Given this list of marker genes PSMB1, MIRLET7A1, YES1, PIK3R3, SUZ12, RICTOR, H2BC4, PAK1, TRAV19, MIR34A, AGO3, ICOS, FOS, PRKAG1, OS9, PPP2R5D, MIB2, HLA-DRB5, PPP2CA, STAT3, PPP2R1A, H2BC9, EP300, MOV10, H2BC13, RBBP5 (RB binding protein 5, histone lysine methyltransferase complex subunit), SRC, MIR142, PSMD11, CD3E, PSMA5, PSMC5, PPP2R5A, HLA-DPB1, H2AZ2, CREBBP, HIF1A, CD3G, PSMC6, CD3D, PSMD1, IRF1, TEAD3, MIR148A, MAGT1, CD80, PIK3R1, CSNK2B, H4C1, CSK, PPP2R1B, TRAC, LYN, CTLA4, UBB, PIK3CD, PSMC3, RBBP4, H3-3A, BTRC, H2BC26, MIR34C, PSMC2, PPP2R5B, PSMA6, HLA-DQB2, MAPKAP1, HLA-DQB1, AKT2, CSNK2A2, H2AC20, BTLA, CUL3, PRKAG2, PDCD1LG2, MIR429, TRAV8-4, PRKAA2, EED, MTOR, AGO4, H2BC1, M, MYC (NCBI Gene Id 731404), H2AC14, WDR5, MIR152, H3C1, GRB2, NEK2, PSMA2, CCND1, CD247, N, PSMB4, HLA-DRB1, PSMA7, RNF185 (ring finger protein 185), DDOST, MIR200C, CSNK2A1, JAK1, SPOP, TEAD4, PSMB7, KMT2A, AKT1, PIK3CG, TUSC3, H2BC12, PIK3CB, VCP, TRBV12-3, RBBP7, H2BC3, ADRM1, MAP3K14 (NCBI Gene Id 9020), MIR34B, AGO2, STT3A, PAK3, PDCD1, SEM1, PSMD3 (NCBI Gene Id 94019), NFE2L2, RELA (NCBI Gene Id 5970), UBC, TMEM258, STAT1, THEM4, TNRC6B, PIK3R5, GRAP2, NFKB2, DERL3 (derlin 3), YWHAG, RBX1, DERL1 (NCBI Gene Id 79139), VAV1, OST4, HLA-DRA, PSMD2, CDK4, GSK3B, UBA52, AKT3, WWTR1, PSMA4, HLA-DQA2, TRAV29DV5, STT3B (NCBI Gene Id 201595), H2AC6 (NCBI Gene Id 8334), PRR5, ICOSLG, COPS5, PSMA3, H2AJ, KMT2C, BRD4, SKP1, H2BC15, PSMA1, PSMD8, PDPK1, PSMB3, MLST8, RNF5, H2AX, TRBV7-9, PSMC1, ERLEC1, CDC42, H2AB1, TCF7, EPAS1, TEAD1, ASH2L, PSMB6, CTNNB1, DAD1, MIR340, HLA-DQA1, HLA-DPA1, MIR424, PRKAB1, PRKAB2, DPY30, JUN, TRIB3, CD274, PPP2R5E, NFKB1, H2AC18, OSTC, H2BC12L, JUND, AGO1, CUL1 (NCBI Gene Id 8454), PPP2CB, MIR140, TCF7L2, PSMC4, RPS27A, ATF3, FYN, LCK, PIK3R2, YAP1, H2BC5 (NCBI Gene Id 3017), PTPN11, TNRC6A, CD86, RPN1, ERLIN1, TNFRSF14, PSMB5, PSMD7, PSMD12, H2AC4, PAK2, MIR93, CD4, PSMB2, FOSB, PSMD14, MYCN, TNRC6C, PRKAG3, CD28, RPN2, B3GNT3, HLA-DRB3, PPP2R5C, H3C15, H2AC7, DERL2, HLA-DRB4, PIK3R6, TRBC1, RAC1, MIR138-1, H2BC17, MAP3K8, PSMD6, TEAD2, MIR200B, SEL1L, LEF1, H2BC14, ERLIN2, PSMD13, PTPN6, PRKAA1, PIK3CA, TCF7L1, H2BC21, H2BC11, EZH2, here is a description of the gene set: Reactome Pathway: Regulation of T cell activation by CD28 family Optimal activation of T lymphocytes requires a carefully orchestrated interplay between two key signals. The first signal originates from the T cell receptor (TCR) recognizing a specific antigen. However, this initial encounter is insufficient on its own. A crucial "costimulatory" signal is needed for full T cell activation, delivered by the engagement of costimulatory receptors, such as CD28, on the T cell surface with their corresponding ligands on antigen-presenting cells (APCs) (Chen & Flies 2013, Acuto et al. 2003, Slavik et al. 1999). <br>The CD28 superfamily is central to costimulation, encompassing a diverse group of receptors including CD28, CTLA-4, ICOS, PD-1, and BTLA. These receptors have both positive and negative influences on T cell activation. CD28 and ICOS provide a positive boost, while CTLA-4, PD-1, and BTLA act as inhibitory brakes. CD28 and CTLA-4 bind to B7 family ligands CD80 (B7.1) and CD86 (B7.2), with CD28 delivering stimulatory signals and CTLA-4 providing inhibitory signals. ICOS interacts with ICOS ligand (ICOS-L), enhancing T cell activation and function. PD-1 binds to PD-L1 and PD-L2, mediating inhibitory signals that modulate the immune response. BTLA engages with HVEM (Herpesvirus entry mediator), transmitting inhibitory signals. This balance between stimulatory and inhibitory signals is essential, allowing the immune system to mount effective responses against pathogens while preventing the induction of T cell unresponsiveness and apoptosis (Chen & Flies 2013, Sharpe & Freeman 2002, Carreno & Collins 2002). <br>The expression of these receptors varies: CD28 is constantly present on naive T cells, whereas CTLA-4 expression depends on prior CD28 engagement. ICOS, PD-1, and BTLA are induced only after initial T cell stimulation. These variations in expression ensure precise regulation of T cell responses at different stages of activation (Sharpe & Freeman 2002). The receptors themselves also exhibit structural differences. CD28, CTLA-4, and ICOS share a single extracellular domain resembling an immunoglobulin molecule (IgV-like). In contrast, BTLA has a distinct structure with an IgC-like domain. Similarly, the costimulatory ligands, such as B7-1 and B7-2, have unique structural features that enable specific interactions with their partner receptors. species: Homo sapiens part of: Adaptive Immune System